Given this list of marker genes UBA5, USP26, UFM1, LBH, SHQ1, TAF1, LMO3, HDAC6, WBP2, DAB2, NCOR2, KMT2D, FOXA1, PAGR1, SRARP, HEYL, CLOCK, KDM4C, VPS18, SAFB, FSHR, UFL1, CREBRF, SAFB2 (scaffold attachment factor B2), ZBTB7A, CALR, CNOT1, UFSP2, SRC, BRCA1, PPP5C, ISL1, PHB2, PRMT2 (NCBI Gene Id 3275), CNOT9, NCOR1, SIRT1, CNOT2, ZNF366 (NCBI Gene Id 195826), PARP1, PER1, DDX5, HDAC1, AR, PHB1, EP300, STRN3, KDM5D, TCF21, TP63, HMGA2, LATS1, PAK1, RHOA, TCF7L2, CARM1, NODAL, MED1, NR0B1, GHRHR, FOXH1, CYP7B1, SKP2, BMAL1, RNF14, HDAC2, DNAAF4, PKN1, CRY1, KDM1A, SFRP1, DDRGK1, KANK2, FOXP1, TRIM68, PIAS2, CDK12, SMARCA4, VPS11, PARK7, CRY2, IGF1, RNF6, here is a description of the gene set: Human Gene Set: GOBP_REGULATION_OF_INTRACELLULAR_STEROID_HORMONE_RECEPTOR_SIGNALING_PATHWAY species: Homo sapiens Any process that modulates the frequency, rate or extent of the activity of any intracellular steroid hormone receptor signaling pathway.